The following is a description of a gene set: Genes up-regulated in cells that have been partially reprogrammed to pluripotency: comparison with the parental lineage-committed cell lines, fully reprogrammed stem cells, and embryonic stem cells. Mouse Gene Set: MIKKELSEN_PARTIALLY_REPROGRAMMED_TO_PLURIPOTENCY from publication Mikkelsen TS, Hanna J, Zhang X, Ku M, Wernig M, Schorderet P, Bernstein BE, Jaenisch R, Lander ES, Meissner A (PMID 18509334) species: Mus musculus Somatic cells can be reprogrammed to a pluripotent state through the ectopic expression of defined transcription factors. Understanding the mechanism and kinetics of this transformation may shed light on the nature of developmental potency and suggest strategies with improved efficiency or safety. Here we report an integrative genomic analysis of reprogramming of mouse fibroblasts and B lymphocytes. Lineage-committed cells show a complex response to the ectopic expression involving induction of genes downstream of individual reprogramming factors. Fully reprogrammed cells show gene expression and epigenetic states that are highly similar to embryonic stem cells. In contrast, stable partially reprogrammed cell lines show reactivation of a distinctive subset of stem-cell-related genes, incomplete repression of lineage-specifying transcription factors, and DNA hypermethylation at pluripotency-related loci. These observations suggest that some cells may become trapped in partially reprogrammed states owing to incomplete repression of transcription factors, and that DNA de-methylation is an inefficient step in the transition to pluripotency. We demonstrate that RNA inhibition of transcription factors can facilitate reprogramming, and that treatment with DNA methyltransferase inhibitors can improve the overall efficiency of the reprogramming process., and this is the list of marker genes: Phox2b, Tfap2a, Perp, Syne2, Slc38a5, Ccnd1, Cdkn1a, Cdh13, Cdkn2a, Foxd1